The following is a description of a gene set: The chemical reactions and pathways involving ornithine, an amino acid only rarely found in proteins, but which is important in living organisms as an intermediate in the reactions of the urea cycle and in arginine biosynthesis. species: Mus musculus Mouse Gene Set: GOBP_ORNITHINE_METABOLIC_PROCESS, and this is the list of marker genes: Otc, Aldh18a1, Azin2, Hnf4a, Asl, Slc25a2, Arg1, Arg2, Oaz1